The following is a description of a gene set: Any process that modulates the frequency, rate or extent of protein catabolic process in the vacuole. studied in species Mus musculus Mouse Gene Set: GOBP_REGULATION_OF_PROTEIN_CATABOLIC_PROCESS_IN_THE_VACUOLE, and this is the list of marker genes: Cd81, Lrp1, Vps35, Ldlr, Mfsd8, Laptm4b, Mgat3, Usp8 (ubiquitin specific peptidase 8), Marchf2, Atp13a2